Given this list of marker genes IL15, IL5, STAT1, STAT5B, IL4, IFNGR2, IL12RB1, STAT6, EPOR, EPO, IFNG, IL12RB2, IL12A, IL2RG, STAT5A, IL2RB, JAK1, IL3RA, IL23A, IFNA1, IL6R, IL2, IL7R, IL7, JAK2, IFNGR1, IFNAR1, IL23R, IL13, IL6ST, STAT2, PIM1, IL15RA, IL4R, IL12B, IL3, JAK3, CSF2RB, STAT3, STAT4, IL13RA1, IL6, IL5RA (NCBI Gene Id 3568), IFNAR2, IL2RA, here is a description of the gene set: Pathway Definition from KEGG: Cytokine -> Receptor -> JAK -> STAT => PIM1 Cytokine-Jak-STAT signaling pathway. Pathway ID: N00053. Pathway type: Reference. Pathway class: nt06263 Hepatocellular carcinoma. Human Gene Set: KEGG_MEDICUS_REFERENCE_CYTOKINE_JAK_STAT_SIGNALING_PATHWAY species: Homo sapiens